The following is a description of a gene set: Mouse Gene Set: GOBP_POSITIVE_REGULATION_OF_INTRACELLULAR_PROTEIN_TRANSPORT species: Mus musculus Any process that activates or increases the frequency, rate or extent of the directed movement of proteins within cells., and this is the list of marker genes: Eif3e, Cdk1, Zic1, Xpo4 (exportin 4), Kif5b, Jup, Gli3, Efcab7, Tenm1, Brca1 (NCBI Gene Id 12189), Hsp90ab1, Rbm22, Pik3r2, Edem1, Edem2, Prkcd, Hcls1, Zpr1, Prkcq, Bcap31, Tpr, Lep, Gas6, Oaz3, Akap5, Anp32b, Mavs, Mapk1 (NCBI Gene Id 98012), Ice1, Ipo5, Prpf4b, Mapk14, Tgfb1, Pdcd5, Sirt6, Nutf2, Ywhae (NCBI Gene Id 22627), Chp2, Pcnt, Oaz2, Ran, Rapgef3, Pik3r1, Ect2, Zfand1, Pdcd5-ps, Ctdspl2, Ptpn5, Shh, Bag3, Commd1, Pcm1, Zc3h12a, Hyal2, Rab29, Xbp1, Ep300, Psen1, Asph, Cep131, Gper1 (NCBI Gene Id 76854), Emd, Pdcd10, Prkaca, Cd81, Kif20b, B3gat3, Ptgs2, Ripor1, Cdc42, Ergic3, Tm9sf4, Nutf2-ps1, Smo, Camk1, Prkd1, Rufy3, Flna, Tardbp, Sec16b, Wipf1, Ubr5, Oaz1, Ifng, Slc51b, Chrm1, Tnfrsf1a, Prr5l, Vamp2, Tmem30a, Jak2, Hdac3, Kif3a, Cep290, Dctn1, Hsp90aa1, Dmap1, Camk4 (NCBI Gene Id 52876), Cdh1, Zdhhc2, Slc35d3, Gsk3b, Il6, Sorl1, Sfn, Tek, Uaca, Plk3, Tmem30b, Trim28, Mdm2, Ppm1a, Ptpn22